The following is a description of a gene set: An abnormality of the renal collecting system. Abnormal renal collecting system morphology Human Gene Set: HP_ABNORMAL_RENAL_COLLECTING_SYSTEM_MORPHOLOGY studied in species Homo sapiens, and this is the list of marker genes: PIGN, PIGY, OTUD5, FANCD2, SIX1, LAMA3, MAPK1, JAG1, FANCE, PSMC1, IARS1, SHOC2, TELO2, RTTN, LAMB3, EYA1, FANCC, TP63, DHCR7, SUCLG1, PIGL, LAMC2, FANCA, PIGA, KDM6A, TNXB, POGZ, COL18A1, KMT2D